The following is a description of a gene set: Mouse Gene Set: HOXC9_TARGET_GENES from publication Yevshin I, Sharipov R, Kolmykov S, Kondrakhin Y, Kolpakov F (PMID 30445619) Genes containing one or more binding sites for (Hoxc9) in their promoter regions (TSS -1000,+100 bp) as identified by GTRD version 20.06 ChIP-seq harmonization. studied in species Mus musculus, and this is the list of marker genes: Gm17494, Hes3, Gm3764, Gm24066, Actn4, Fpgs, Tcea1, 5730596B20Rik, Dthd1, Micu3, Krt13, Gm15413, Prex2, Rufy3, Gm5446, Fggy, 9230020A06Rik, Rcan2, Snord13, Gm15050, Clrn1, Mir760, Gm25541, Nr2f1, Tmtc2, Snora17, Adh6b, Arg1, Lman1, BC034090, D3Ertd751e, Ndst4, Etfb, Bfsp2, Adamts5, Unc13b, Cnr1, Baalc, Csrnp3, Adh4, Npsr1, Hoxc4, Klhl35, Hoxd4, Ldlrad3, 1110059E24Rik, Mrtfb, Gm13001, Amd-ps3, Tpm3 (NCBI Gene Id 59069), Gm15577, Mpp3, Stam, Smad3, Gm29200, Hoxb7, Tshz2, Trp53bp1, Eif4e3, Gm12295, Alyref2, Zbtb20, Spink7, Cdca7, Gm30382, Taf3, Steap3, Rad23a, Nmnat3, Atf6 (activating transcription factor 6), 2610307P16Rik, Oacyl, AU020206, Dennd1b, Gm26791 (NCBI Gene Id 73306), Rps13-ps5, Khdc4, Gm2824, Gm26748 (NCBI Gene Id 102635772), Sez6, Mir1b, Mir10a, Lingo2, 2700033N17Rik, Hoxb9, Fam110b, Angel1 (angel homolog 1), Enox2, Gm16794, Hoxc6 (NCBI Gene Id 15425), Hmgn3, Tcf12, 2810471M01Rik, Arpp19, Ctps1, Tstd2, Pde10a, Zfp407, Camk4, Serpinb13, Gm14216, Gm8022, Ttll11 (NCBI Gene Id 99233), Ror2 (receptor tyrosine kinase-like orphan receptor 2), Gm24547, Ubl3, Skida1, 9930014A18Rik (NCBI Gene Id 320469), Cpsf4l, Alg9, Mrpl33, Dct, Pkd2l1, Gnb1, Sox2ot, Gsto2, 1200007C13Rik, Nhlh2, Dynll1, Gm11191, Gm35394, St18, 4930518C09Rik, Sptlc2, Rapgef6, Gm12224, Gm22488, Gm25918, Mrm2, Gm15941, Jazf1 (NCBI Gene Id 231986), Hoxd3, Oxnad1, Hat1, Bbs2, Raet1e, Slc1a2, Prpsap1, Rasa1, Vrk3, Efnb2, Myo10, A730089K16Rik, 4732491K20Rik, Tcte2, Arhgef9, Mrps33, Gm3235, Ranbp17, Gtf2f2, Ccdc60, 4930486I03Rik, Gsk3a, Cyp4f17, Nrarp, 6430511E19Rik, Ank2, Gm20052, Jarid2, Ypel1, Dph3b-ps, Uts2b (NCBI Gene Id 224065), Arhgap28, Gm5127, Cdk14, Atxn7l1, Srbd1, Nfyc-ps, Nyap2, 5930403N24Rik, Ccdc174, Lrba, Gm19325, Tmem87b, Mapk1, Bpifb3, Aktip, Slit3, Mir99ahg, Tenm3, Gm24355, Dab1, 9330175M20Rik, A130014A01Rik, Anp32a, Reep3, Sgpp1, Rhobtb1, 4921534H16Rik, Slc1a1, Postn, Pik3r1, Ajuba, Gm36241, Marcks, Gm12408, Gm9934, Frmd8os, Mpzl3, Pbx3, Slc25a39, Tcf4, Ppip5k2, Bnc2, Papola, Dnah5, Sc5d, Clvs1, Slc37a3, Cfap126, Slit2, Sipa1l3, Plxna2, Slc26a5, Mir763, Hsdl2, Cdcp2, Hoxb8, Agk, Phyhipl, Tnfsf13b, Rapgef2, Gpm6a, Slc35f5, Asic5, Gm10645, Mtnr1a, Zbtb18, Mycl, Nfasc, Gm16305, Hdx, Dll1, Slc31a2, Runx1t1, Zfp42, Taar2, Ccng2, Izumo1, P2rx3, Gm22268, C79798, Ccdc171 (coiled-coil domain containing 171), Clcn3, C820005J03Rik, Emid1, Sec61a2, Grhl2, Eps8, Fam110d, Hoxa3, Meig1, Schip1, Gm25828, Enpp3, Ing3, Shisa3, Cacna1b (NCBI Gene Id 99436), Sec24d, Cdhr3, Gm12126, Prrx1, Gnat3, Zmat4, Dcdc2a, Exoc4, Srsf9, Otud7a, Shroom2, Auts2, Mfhas1, Cables1, Gm34727, Mtarc1, Crp, Lin28b, Sfxn5, Fam13c, Got2, Rabl6, Map3k4, Stk39, Gm9929, Wdr6, F730016J06Rik, Gm10177, Meis1, Mn1, Prdm8, Mir199a-2, Plch2, Meis2, Hoxb5, Tbce, Nacc2, Foxd3, Stk33, Sema3a, Lars2, Hdac9, Zfp664, Mpped2, Ngef, Atxn7l1os2, Garre1, Kcnv2, Gm13450, 6430562O15Rik, Exoc1l, Gm15407 (predicted gene 15407), Arid4a, Tnks2, Gm12676, Tti2 (TELO2 interacting protein 2), Fzd10, Ankrd13a, 3110099E03Rik, Rora, Slc5a12, Meis3, Ttc8, Mir5129, Aqp9, Lpl, Lta4h, Mir9-3hg, Zfp949, Gm11228, Mmp9, Plch1, Stra6l, Lgr4, Selenof, Pgm2, Gcnt2, Gm3443, Zeb2os, Mir6540, Gm8109, Hpgd, Slc9a6 (NCBI Gene Id 236794), Pax6, Elavl4, Halr1, Gm13652, Alpk1 (alpha-kinase 1), 8430419K02Rik, Gm4895, Adipor2, H60b, Nepn, Med13l, Stat2, Cntn6, Pde9a, Marchf3, Spp2, Pdzrn4, Ptprc, Myt1, Ncstn, Reln, Dhx40, Hoxaas3, Atxn7l3b, Bco1, Mybpc1, Gm23453, Vipas39, 6530411M01Rik, E030025P04Rik, Klhl5, Mir7230, Zc3h11a, Lrmda, Npepl1, Hoxb3, Ptpn6, Clk4, Megf11, Nr6a1os, 2600014E21Rik, Mir219a-2, P4ha3, Bhlhe22, 4930503O07Rik, Il1rn, Arfgef1, Ddc, Tspan5, Tfrc, Topbp1, Gm6884, Tmem65, Gm29507, Gm47290, Coq10a, Mir615, Nf2, Ptprr, Kmt5a, Gm28530, Gm11217, Hoxa5, Elmo2, Pla2g2e, Pax6os1, Stat4, Lmo3, Smarca2, Zfp945, Gm13629, Gm14053, Gm12119, Chrna4 (NCBI Gene Id 11438), Hoxb5os, Tgif1, Cobll1, Ear-ps4, Mir124-2hg, Celf3, Gm24373, Tead1, Cmtr1, Cdh6, Gm23234 (NCBI Gene Id 115486365), Gm24454, LTO1, Rhob, Spock2, Parva, Nploc4, Lrig1, Zmat1, Cntn5, Gm26970, Cfap61, Tfpi, Dpp4, Ubp1, Rgma, Echdc1, Cct5, BC028471, Bhmt1b, Trmu, Rpgrip1, Arhgap8, 2010106C02Rik, Psd3, Gtpbp1, Fbxw7, Ass1, Gm26509, Gm10655, Cpa6, Hoxa2, Camk2d, Tmem97, Btf3l4, Tle3, Apcs, Tyw5, Tmem178b, Pold1, Suco, Tro, Gng2, Nudt1, Clasp1, Nbea, Cep112, Gnb5, B230216N24Rik, Fryl, Sos1, Dapk2, E4f1, Srgap2, Tshz1, Gm31881, Klhl1, Gm13421, 9530003O04Rik, Gm12689, Igf1os, Gm32736, Mir1897, G630022F23Rik, Sumf1, Gm13990, Iqsec1, Rgs8, Hoxaas2, Cdnf, Nudt4, Rbm25, Wwp1, Slc18a1, Mkrn1, Tcim, Dnmt3a, Zfp672, Adam12, Lrrtm2, Mir873a, Rasgrp2, Gm10637, Ercc5, Zfp710, Ano4, Gm7799, Cux2, Bvht, Palld, Wdr95, Rasal2, G630016G05Rik, Fer1l6, Gm20714, Gm29508, Slamf8, Gm13134, Mirlet7c-1, Cttnbp2, Fam181a, Cox20, Mir8093, Gm5335, Zeb2, Grip1os2, Fgfr2, Cux1, Gm4791, A430027C01Rik, Krt9, Cers6, Rbm5 (RNA binding motif protein 5), Insc, Ngdn, Vwa8, Esco1, Mir124a-2, Zar1, Gm16141, A530020G20Rik, Ptger2, Rab15, 4933430M04Rik, Ccnl1, Kcnip2, Hmgn2, Ermap, Wipf1, Gm36017, Prdm13, Cacna2d2, Tmem178, Dnajc1, Pgbd5, Pla2g2d, Acad11, Pcdhgc4, Gm26944, Nkx6-3, Gm16876, Larp1b, Tsga13, Gm12688, Dnm3os, Zfp473, Hdac4, Tox, Fam110a, Zfp423, A330040F15Rik, Ncam1, 4930512H18Rik, Vapb, D830032E09Rik, 9430053O09Rik, Gm8182